The following is a description of a gene set: SLBP Dependent Processing of Replication-Dependent Histone Pre-mRNAs Human Gene Set: REACTOME_SLBP_DEPENDENT_PROCESSING_OF_REPLICATION_DEPENDENT_HISTONE_PRE_MRNAS studied in species Homo sapiens, and this is the list of marker genes: SNRPB, ZNF473, NCBP1, SNRPG, LSM10 (NCBI Gene Id 84967), LSM11, SNRPE, SNRPF, NCBP2, SNRPD3, SLBP